The following is a description of a gene set: The process whose specific outcome is the progression of a glomerular mesangial cell in the kidney over time, from its formation to the mature structure. species: Mus musculus Mouse Gene Set: GOBP_GLOMERULAR_MESANGIAL_CELL_DEVELOPMENT, and this is the list of marker genes: Notch1, Gpr4, Foxc2, Acta2 (actin alpha 2, smooth muscle, aorta), Pdgfb